The following is a description of a gene set: Human Gene Set: AIZARANI_LIVER_C39_EPCAM_POS_BILE_DUCT_CELLS_4 from publication Aizarani N, Saviano A, Sagar, Mailly L, Durand S, Herman JS, Pessaux P, Baumert TF, Grün D (PMID 31292543) studied in species Homo sapiens, and this is the list of marker genes: TPM1, CD151, MAFF, HSPB1, EPHA2, LAMP2 (NCBI Gene Id 3920), INHBA, CX3CL1, LAD1, ALCAM, S100A11 (S100 calcium binding protein A11), CSF1, TRPV6, ANXA2, DCDC2, SDC4, PKHD1, CHST4, TNFRSF21, EDN1, TRIM47, SORBS2, CREB5, CRYAB, MYO1C, SPINT2, SOD2, DST, CD24, CCNL1, PIM3, VMP1, NEDD9, CTBP2, SLC12A7, RAB11FIP1, SLC12A2, TNFRSF12A, HSP90AB1, ALDH3A2, ANXA4, SPATS2L, ADAM9, TRNP1, CDH1, CDC42EP1 (CDC42 effector protein 1), ITGB1, TPM4, SLC3A2, EGFR, LIF (LIF interleukin 6 family cytokine), ELF3, ITGB8, S100A14, ACTN4, MYO6, HMGCR, CXCL8, PMEPA1, TNKS1BP1, NUAK2, CLDN1, MYADM, GDF15, MMP7, UBE2B, ITPKC, SYNE2, LAMB3 (laminin subunit beta 3), EZR, C6orf132, NRG1, HDGF, RTN4, CCL2, GADD45A, RASSF8, ENAH, CLDN7, OCLN (NCBI Gene Id 4950), TNFRSF10B, PHLDA2, COBL (cordon-bleu WH2 repeat protein), UCA1 (urothelial cancer associated 1), NFKB2, SCARB2, TNFAIP2, AHNAK, CD47, SLC7A1, ABCB1, PKP4, CD63, KDM6B, KRT19, FSTL3, MSMO1, MCAM, KRT7, KRT8, SERPINA3, ACTG1, IFNGR2, BICC1, ANXA5, HSPA1A, TM4SF4, SOX4, IRS2, UGCG, BIRC3, CLDN4, TM4SF1, SGMS2, EPCAM, SYNJ2, ZYX, TUBB6, CXCL3, TJP1, SFRP5, HMGCS1, CALM2, MAP4, NCEH1, MET, NFKB1, FLNB, WEE1 (WEE1 G2 checkpoint kinase), ATF3, CXCL6, MYH9, KLF6, KLF5, SPSB1, CITED4, SPTBN1, TACSTD2, RAB3IP, ZBTB20, ATP1A1, KRT80, BMP2, DSG2, APLP2, ATF4, S100A6, PFKP, DSP, SOX9, HSPA1B, VEGFA, HBEGF, IL32, CRIM1 (NCBI Gene Id 51232), BAZ1A, HSP90AA1, CFTR, NCOA7, VCL (NCBI Gene Id 7414), LAMC2, GPRC5B, FLNA, THBS1, CD59, YWHAE, BCL2L1, CXCL1, ANKRD1, CCL20, AFDN, DEFB1, RRBP1, TP53BP2, PDLIM1, TENT5A, SAT1, KRT18, NFKBIA, CPM, SQSTM1, SLC5A1, RNF19A, FGFR2